The following is a description of a gene set: A protein complex that has growth factor activity. Human Gene Set: GOCC_GROWTH_FACTOR_COMPLEX studied in species Homo sapiens, and this is the list of marker genes: PDGFB, PDGFA, IGFBP6, IGF1, IGFBP3, VEGFA, IGFALS, IGFBP5